The following is a description of a gene set: The active transport of neurotransmitters into a synaptic vesicle. This import is fuelled by an electrochemical gradient across the vesicle membrane, established by the action of proton pumps. Human Gene Set: GOBP_NEUROTRANSMITTER_LOADING_INTO_SYNAPTIC_VESICLE studied in species Homo sapiens, and this is the list of marker genes: SLC18A2, SLC17A7, SLC17A8, SLC32A1, SLC17A5, SLC17A6, SLC18A1